The following is a description of a gene set: CD4 T follicular helper (Tfh) cells provide the required signals to B cells for germinal center reactions that are necessary for longlived antibody responses. However, it remains unclear whether there are CD4+ memory T cells committed to the Tfh lineage after antigen clearance. Using adoptive transfer of antigen-specific memory CD4+ subpopulations (based on CXCR5 and Ly6c expression)in the LCMV infection model, we found that there are distinct memory CD4+ T cell populations with commitment to the Tfh and Th1 lineages. Our conclusions are based on gene expression profiles, epigenetic studies and phenotypic and functional analysis. The gene expression profiles of virus-specific CD4 T cell subets at effector and memory stages is presented here. Human Gene Set: GSE43863_TH1_VS_TFH_MEMORY_CD4_TCELL_DN Genes down-regulated in CD4 SMARTA memory T cells: Th1 versus follicular helper (Tfh). from publication Hale JS, Youngblood B, Latner DR, Mohammed AU, Ye L, Akondy RS, Wu T, Iyer SS, Ahmed R (PMID 23583644) species: Homo sapiens, and this is the list of marker genes: HK1 (NCBI Gene Id 59333), DENND1C, LSR, HLA-DOB, IFT140, ITK, PIAS3, NUMA1, GIT2, RIPOR2, EVI2B, BIN1, SERINC3, GM2A, KDM7A, ICOS, TNFRSF18, RCSD1, CERK, SEMA4B, TSC22D3, MYH9, HSD17B11, LRRCC1 (leucine rich repeat and coiled-coil centrosomal protein 1), HLA-DRB1, DGKD, LAMP1, CNN2, PHC2 (NCBI Gene Id 1912), IFT172, PTPRC, PARP1, DTX1, PTPN22, ABCA1, STAU1, ITPRIP, TK1, ATOSA, ITPR3, HS3ST1, BMF, INTS6L, ZNF496, PLEKHG2, RABEP2, PDE2A, PLEKHA2, FCGR2B, EPAS1, ZNF414, CERS4, CTSA, CARMIL2, TRIB2, ROGDI, STX2 (NCBI Gene Id 6808), HBP1, CYB561A3, HHEX, ARHGEF18, TMEM51, MRGPRE, CYTIP, HLA-DMA, TOR4A, GABARAP, NIT1, GOT1L1, KLF13, PLP2, EGFL6, CBL (Cbl proto-oncogene), ANKRD13A, YPEL3, FAM53B, HIP1R, PIK3CG, CDKN1B, RAB1B, CD74, ADAM8, ARID3A, UNC119B, ZNF395, MICAL1, LRSAM1, MSN, ETS1, IFI30, SPAG9, RIN3, VCL, ZNF821, CDC42EP3, ADAMTS10, RGS3 (NCBI Gene Id 5998), WDR81, LEPROTL1, ADD3, LMNTD1, ARHGEF3, AFF1, JAK2, CALHM2, POU6F1, PIANP, MAK, MIDEAS, STK17B (NCBI Gene Id 9262), SIDT1, CCR6, PDE3B, RMND5B, HGS (NCBI Gene Id 9146, hepatocyte growth factor-regulated tyrosine kinase substrate), TRPV2, PRIM2, ABCB4, SEMA4D, LPP-AS2, EIF2AK3, MAP4K2, BMP2K, SPIB, RGL2, ABCG2, ID3, WNT10A, SUSD1, CTSO, GPR34, MBD4, CEMIP2, CDT1, ADCY7, UAP1L1, FCRLA, CSNK1G2, CREBRF, TUBB2A, PTPRO, FRMD8, MAN2A2, ADD1, IL2RG, ERP29, POU2AF1, CCNG2 (NCBI Gene Id 901), SMAD6, PLEC, SLC12A6, SMIM14, ABCD1, HPSE, SCARB2, CDC42SE2, ANKH, ERCC5, RNASE6, FGD3, CTDSP2, GMIP, DYNLT3, PRSS23, GLI3, PIGP, NOXO1, TRIM8, CPT1A, SMC6, LAT2, TPD52, SUSD3, HELZ, RERE, ARHGEF1, ZNF608, SLA, RP9, GTPBP2, PPDPF, SH3BP1, MGAT1, KDM2A, RNF167, TRAF3IP3 (TRAF3 interacting protein 3), IFNGR1, ZMYM5, CTSW, AP3B1, WASF2, ERO1B, OSBPL9, SNAI3, PARP4, TSPAN13, PIP4P1, MAPK11, C1orf54, TMEM9B